The following is a description of a gene set: Human Gene Set: MIR10526_3P from publication Chen Y, Wang X (PMID 31504780) Genes predicted to be targets of miRBase v22 microRNA hsa-miR-10526-3p in miRDB v6.0 with MirTarget v4 prediction scores > 80 (high confidence targets). studied in species Homo sapiens, and this is the list of marker genes: FAM110B, MAX, TCF7L2, AAK1, MAL2, ADA2, RRP15, DLG3, CNMD, KLF12, NNAT, CMC2, RPS6KA6, NUFIP2, RBM4B, C2CD2L, PSMA4, NECTIN1, MAP3K21, CALML4, ANKIB1 (ankyrin repeat and IBR domain containing 1), KAT6A, CADM2, TPTEP2-CSNK1E, SELENOI, KDM4A (lysine demethylase 4A), EPPIN, GALNT11, PROM2, MYH9, XPNPEP1 (X-prolyl aminopeptidase 1), RFFL, MOB1B, INO80D, PDIA3, GJA3, CBL, SLC39A11, ARRDC3, PPP2R5B, GATAD2B, GLYATL3 (glycine-N-acyltransferase like 3), POU2F1, L3MBTL1, HIF1A, ARID1A, UBXN7, SYNCRIP, WARS2, SHOX2, CPNE2, CSRNP2, EPHA4, NOVA2, TOB2, FAXDC2, VSTM2A, GOLGA1, OTUD6A, ABCG1, CDSN, RNF2, PLEKHH2, ACVR1C, MYCL, TSPAN8, ZFHX3, TARBP1, SPINK8, FAM171A1, ANOS1, POU3F4, DOK5, OLFM3, MUCL1, VAPA, REM2, NR4A2, PABIR2, SPTLC2, TCFL5, FIGN, DNAJB14, ZNF543, ACSM5, PTK2, SPRY2 (NCBI Gene Id 10253), PLEKHA6, IL1RAP, CACNA2D1, ATG13, MEX3D, PIGK, RAB3IP, SPATA6L, GRAMD1B, SRSF6, MAK16, PPP5C (protein phosphatase 5 catalytic subunit), TNFAIP1, NAPEPLD, DPF2, OTULIN, TNIK, MAFG, GPR12, MARCHF6, PNMA8A, ATAD2B, HACD3, CADM1, ATF6, WASF2, SMAD9, NAV1, ADAM19, CSNK1E, ARRB1 (NCBI Gene Id 408), POGZ